The following is a description of a gene set: FASTK family proteins regulate processing and stability of mitochondrial RNAs species: Homo sapiens Human Gene Set: REACTOME_FASTK_FAMILY_PROTEINS_REGULATE_PROCESSING_AND_STABILITY_OF_MITOCHONDRIAL_RNAS, and this is the list of marker genes: MT-RNR1, MT-RNR2, FASTKD2, TBRG4, FASTKD5 (NCBI Gene Id 60493), FASTK